Given this list of marker genes Gtf2h3, Gtf2h5, Ercc2, Gtf2h4 (NCBI Gene Id 14885), Mnat1, Ercc3, Gtf2h1, Ccnh, Cdk7, Gtf2h2, here is a description of the gene set: Mouse Gene Set: GOCC_TRANSCRIPTION_FACTOR_TFIIH_CORE_COMPLEX studied in species Mus musculus The 7 subunit core of TFIIH that is a part of either the general transcription factor holo-TFIIH or the nucleotide-excision repair factor 3 complex. In S. cerevisiae/humans the complex is composed of: Ssl2/XPB, Tfb1/p62, Tfb2/p52, Ssl1/p44, Tfb4/p34, Tfb5/p8 and Rad3/XPD.